The following is a description of a gene set: studied in species Homo sapiens from publication Yevshin I, Sharipov R, Kolmykov S, Kondrakhin Y, Kolpakov F (PMID 30445619) Human Gene Set: ZNF112_TARGET_GENES Genes containing one or more binding sites for (ZNF112) in their promoter regions (TSS -1000,+100 bp) as identified by GTRD version 20.06 ChIP-seq harmonization., and this is the list of marker genes: FTO, NEK7, RNU6-1224P, ANGEL1, MYO18B-AS1, SHFL, TAB2-AS1